Given this list of marker genes ACTR5, INO80B, NFRKB, MCRS1, RUVBL2, UCHL5, YY1, RUVBL1, ACTL6A, INO80, YY1AP1, INO80E, INO80C, INO80D, TFPT, ACTR8, here is a description of the gene set: species: Homo sapiens A multisubunit protein complex that contains the Ino80p ATPase; exhibits chromatin remodeling activity. Human Gene Set: GOCC_INO80_COMPLEX